The following is a description of a gene set: Reactome Pathway: TGFBR3 expression species: Homo sapiens This pathway describes the transcriptional and translational regulation of TGFBR3. Regulation of TGFBR3 expression includes different transcription factors (Sp1, MyoD and RAR), epigenetic regulators such as HELLS and KLP16), and translational regulation by miRNAs. part of: Signaling by TGFBR3, and this is the list of marker genes: EP300, MYCN (MYCN proto-oncogene, bHLH transcription factor), TGFBR3, MYOD1, TCF4, MYF6, AGO2 (NCBI Gene Id 286109), TNRC6C, RXRA, TCF3, MOV10, MIR27B, KLF16, MYOG, RARA, TCF12, MIRLET7A1, SP1, AGO4, SMAD3, TNRC6B, HELLS, TNRC6A, AGO1, AGO3, SMAD4, MIR23B (microRNA 23b), MYF5